Given this list of marker genes TANC2, GPR85, ASAH2, PCGF2, CD2AP, RSBN1, TRAM1L1 (NCBI Gene Id 133022), TTC39C, MYCL, CDC42BPA, RPS6KC1 (NCBI Gene Id 26750), PELI1, TAOK3, EIF5A2, SCN3B, HTR2A, CYSLTR2, RAB13, BTLA, GCNT4, TAOK1, TPBG, SP2, RABGAP1L, FMNL2, XAF1, GXYLT2, PRPF40A, PIGZ, DPYD, QSOX1, OASL, SATB1, TRIM21, CALHM5, CCL5, LCP2, ACTN1, CRB1, SFMBT2, GCA, TPPP3, ITGB8, EFCAB10 (EF-hand calcium binding domain 10), DCBLD2, SMURF1, GRAMD2B, ELL3, LPAR1 (NCBI Gene Id 1902, lysophosphatidic acid receptor 1), ATP10A, CPA4, FKBP14, ACOD1, POLR2G, TAF9B, ABI1, MAP1LC3A, SGMS1 (sphingomyelin synthase 1), TEC, HEBP1, GKAP1, PSME1, FAP, IFIH1, MARCKS, SOCS7, PLOD2, SYNE2, NIPAL1, PKIB, FOXP1, TLR3, PRPF38A, RCN1, ARHGEF12, IL21, KDR, ISG15, FRMD4B, ABHD6, ANKRD44 (NCBI Gene Id 91526), IL6, ANGPTL3, DST, ZHX2, HAP1, MAGED1, DTNB, MMP10, BFSP2, ACOT9, EDNRB, RSAD2, SP110, RASGRP1, REL, TUT4, ACSF2, GNB4, HECW2, FTMT, OSGIN2, UACA (uveal autoantigen with coiled-coil domains and ankyrin repeats), IFI16, LRRC15, MAGOHB, NEURL3, PTTG1, ARHGEF3, BCORL1, RAC3, DCAF12L1, TREX1, PSMB9, NETO2, ARHGAP5, STARD8, STAU2, KLF8 (NCBI Gene Id 11279), HECTD2, IL13RA1, NPHS2, NT5C3A, GPBP1, CYP2R1, MX2, NR2F1, GTPBP4, IL7, AIG1, MAGED2, KDM5B, AIM2, FAH, CXCL10, ADGRG6, NINL, PTCH1, MMP13, ZC2HC1A, CDC42BPG, ZDHHC2, BRWD1, SLC30A4, MAPK11, TTC39B (tetratricopeptide repeat domain 39B), CRIM1, GRID2, RNASEH1, VOPP1, IFNB1, TTC3, CD69, IMMP2L, SVBP, HCN2, STAG2, AHR, GBP2, MRAS, here is a description of the gene set: studied in species Homo sapiens from publication Hoffmann R, Lottaz C, Kühne T, Rolink A, Melchers F (PMID 17890238) Human Gene Set: GSE4590_PRE_BCELL_VS_LARGE_PRE_BCELL_UP Genes up-regulated during B lymphocyte differentiation: pre-B I versus large pre-B II. Cells from four develppmental stages were purified by FACS from human bone marrow samples